Given this list of marker genes HLA-DQA1, NLRC4, NLRP3, CD58, SIRPA, RXRA, NFKBIA, TYROBP, C1QC, TNFAIP3, CD86 (CD86 molecule), NOD2, TLR4, C1QB (NCBI Gene Id 713), C1QA, RIPK2, LY96, here is a description of the gene set: Human Gene Set: NAKAYA_PBMC_FLUAD_MALE_AGE_14_27YO_1D_POSTBOOST_VS_0D_PREIMM_MF59_ADJUVANTED_1DY_GENES_IN_BTM_M40_AND_M53_UP The dynamics and molecular mechanisms underlying vaccine immunity in early childhood remain poorly understood. Here we applied systems approaches to investigate the innate and adaptive responses to trivalent inactivated influenza vaccine (TIV) and MF59-adjuvanted TIV (ATIV) in 90 14- to 24-mo-old healthy children. MF59 enhanced the magnitude and kinetics of serum antibody titers following vaccination, and induced a greater frequency of vaccine specific, multicytokine-producing CD4(+) T cells. Compared with transcriptional responses to TIV vaccination previously reported in adults, responses to TIV in infants were markedly attenuated, limited to genes regulating antiviral and antigen presentation pathways, and observed only in a subset of vaccinees. In contrast, transcriptional responses to ATIV boost were more homogenous and robust. Interestingly, a day 1 gene signature characteristic of the innate response (antiviral IFN genes, dendritic cell, and monocyte responses) correlated with hemagglutination at day 28. These findings demonstrate that MF59 enhances the magnitude, kinetics, and consistency of the innate and adaptive response to vaccination with the seasonal influenza vaccine during early childhood, and identify potential molecular correlates of antibody responses. Genes up-regulated in peripheral blood mononuclear cell 1d postboost vs 0d pre-imm in children (14-27m) (MF59-adjuvanted) after exposure to Fluad, time point 1D. Comment: (C) Genes in BTM M40; (D) Genes in BTM M53 from publication Nakaya HI, Clutterbuck E, Kazmin D, Wang L, Cortese M, Bosinger SE, Patel NB, Zak DE, Aderem A, Dong T, Del Giudice G, Rappuoli R, Cerundolo V, Pollard AJ, Pulendran B, Siegrist CA (PMID 26755593) studied in species Homo sapiens